Given this list of marker genes Tek, Abcb1b, Prr5, Tamm41, Vta1, Cfap54, Brf2, Itgb4, Plscr2, Cbfa2t3, Dvl3, Phpt1, Gcat, Krt10, Gstm3, Arhgap32, Entrep3, Shfl, Epyc, Fnbp1l, Tgif1, Il12rb1, Nlrp4b, Tcea2, Osbpl3, Tsks, Chchd6, Zcchc3 (zinc finger, CCHC domain containing 3), Ush2a, Ppil4, Ncam2, Dusp7, Nkain1 (NCBI Gene Id 72746), Snord8 (small nucleolar RNA, C/D box 8), Csn1s2a, Parm1, Glycam1, Klf4, Ift22, Rrp1b, Cd93, B630019K06Rik, Dag1, Pcmtd1 (NCBI Gene Id 71455), Rhbdd2, Gimap5, Rab37, Acad9, Nt5c3b, Trp53rkb, Fnbp4, Abcf2, Lgi4, Rmnd1, Pik3ip1, Kifbp, Mylk, Smad9, Pskh1, Gm7967, Irak1, Prkch, Armc10, Crem, Tmtc2, Dip2c, Rnf138, Arhgef2, Mgat3, Gata2, Plekhf1, Igf2bp1, Mtf2, Ptprcap, Garin5a, Ergic1, Zbtb38, Gm8883, Ptpdc1, Fhl4, Ppic, Ptgds, Afap1l1, C4b, Ptov1, Abi2, Acad8, Fbxw24, Wdr19, Bvht, Abcb11, Lgals3bp, 2410018L13Rik (RIKEN cDNA 2410018L13 gene), Capsl, Casp8, Kank2, Gadd45b (growth arrest and DNA-damage-inducible 45 beta), Nrgn, Clasrp, Pou2f2, Abl1, Rhobtb3, Rapgef5, Slc39a6, Trim32, D630045J12Rik, Mef2c, Gm11844, Pafah2, Hspa1l, Acot2, Cdk9, Ccdc90b, Slc12a7, Vwa8, Ino80e, Zfp326, Lhpp, Ifi203, Ascl1, Arhgef17, Tmem135, Slc1a1, Nell1, Tmsb10, Endou, Il11ra1, Tnik, Ushbp1, 1700092E19Rik, Rlim, 2310002L09Rik, ENSMUSG00000137801, Hoxa6, Sox4, Taf4b, Thsd1, Snapc1, Slc4a1ap, Smyd5, Gm31597, Dnajb9, Ccar1, Hoxa9, Sh2b1, Repin1, Crtc1, Pdcd6ip, Ptx4, Fgf18, Cwf19l1, Mdga1, Saraf, Nrg4, Actr3b, Miga1, Gja1, Hes2, Spart, Cep170b, Ttc27, Zmym4, Tnfaip8l1, Phc1, Rpusd4, Sms (spermine synthase), Fzd8, Terf2, Hmox2 (NCBI Gene Id 15369), Lats2, Ago1, Smo, Lrrc1, Gm11772, Anxa10, Stox2, Ccnd2, Efna1, Spred1, Pemt, Hoxa4, Alkbh6, Ctla2b, Per2, Dnajc1, Tymp, Avpi1 (NCBI Gene Id 69534), Hs1bp3, Clca2, Eva1b, Usp2, Hephl1, Epb41l4b, Rbakdn, Plxdc2, Rnf217, Gm27343, Rassf2, Ecpas, Ltbr, Sytl4, Hmga2, Mmp23, Egln3, Fchsd2, Plppr2, Asrgl1, Lix1l, Plppr3, Spmip6, Art1, Mn1 (NCBI Gene Id 634779), Elovl6, Serpinf1, Gemin5, Septin1, Acnat2 (acyl-coenzyme A amino acid N-acyltransferase 2), Tfpi, Naa25, Nwd2, Adgrl4, Norad, Gbp3, Mlxipl, Fbln2, Ttc21b (NCBI Gene Id 73668), Klhl3, Slc4a8, Zpbp, Arhgef5, Deptor, Prdm5, Dhtkd1, Islr2, Syde1 (synapse defective 1, Rho GTPase, homolog 1 (C. elegans)), E130311K13Rik, Slc25a36, Snx30, Dnmt3b, Kdelr1, Cand2, Usp30, AU020206, Pkp4, Msi2, Usp28 (NCBI Gene Id 235323), Cpeb1, Kcnc1, Mlec, Hic1, Scn8a, Fgf10, Foxb1, Aldh5a1, 9030619P08Rik, Nop14, Ptprm, Ipo4, Gulp1, Nalf1, Hmgn5, Tctn1, 4933406I18Rik, Cyp4v3, Ift46, Acsm1, Tnfsf10, Ntrk3, Pgpep1 (pyroglutamyl-peptidase I), Dagla, Tamalin, Csrnp1, Cend1, Tpk1, Tes, Paip2b, Ttc22, Mtor, G730003C15Rik, Cnrip1, Grp, Mprip, Ints12, Enah, Ralgapb (Ral GTPase activating protein, beta subunit (non-catalytic)), Ceacam12, Pnpla6, Nav1, Zfp704, Taok3, Gpr15lg, Uqcc1, Gimap6, Akap6, Kifap3, Lingo3, Rwdd3, Ildr2, Cd27 (CD27 antigen), Rps25, Obp2a, 4930444F02Rik, Armcx2, Etv6, Slc35f2, Nek6, Esam, Prss8, Fkbp3, Gstm1, Sestd1, Fabp9, Amer1, Bnip5, Stxbp1, Zfp787, Kcnmb1, Phf3, Prkce, Spock2, Stambp, Dicer1 (dicer 1, ribonuclease type III), Atf6b, Pogk, Klf12, Uba52, Dusp12, Hdhd5 (NCBI Gene Id 94046), Syt11, 1700025G04Rik, Kat2a, Pdrg1, Zfp629, Pgm1, Ube2e2, Cnot1, Bod1, Taf1d, Glis2, Mccc1, Apoa5, Zfp945, Mfng, Fads2, Firre, Dapk1, Kcnj14, Tmem176b, Zfp12, Mtmr10, Gmppb, Smad1, Ddx11, Fzd6, Sod2, Exoc3l2, Gm5602, 2810403D21Rik, Fbxo21, H2-Q10, Ift56, Carmil2, Cibar1, Zfp827 (zinc finger protein 827), Meis1, Hint2, Gprasp2, Hp1bp3, Itpr1, ENSMUSG00000143154, Gpn1, Rs1, Cbfa2t2, Eprs1, Flt3, Fbxw11, Fkbp1a, Zfp422, Flnb, Wnt6, Clip4, L3hypdh, Fasn, Cysltr1, Htr2a, Mus81, Dennd2d, Trp53i11, Tacr2, Hnrnpu, Gimap9, Pitpnm2, Kctd1, Ears2, Spmip10, Galnt11, Pgrmc1, Arl3, Tcerg1l, Midn, Rcn2, Prl2a1, Meaf6, Nkapd1, Gopc, Pced1a, Zxdb, Mpped2, Gm30431, Dhdh, Hspa4, 2900026A02Rik, Slc17a5, Itgb8, Slc5a6, Rhobtb1, Sfr1, Npl, Fam43a, Dlg3, Gtf3c6, Kremen1, Prss12, Rbmy, Tbc1d16, Insr, Ankrd37, Nipsnap1, Clec14a, Akr1b7, Lrrc58, Adgrg1, Ivns1abp, Limd2, Ada, Mxd4, Kazn, Syngr1 (NCBI Gene Id 98000), Krt18, Kit, Ttpa, Btc, Mapk6, Disp1, Arpp19, Fbxl19, Mrpl19, Hic2, Bfar, Ctbp2, Rnf152, Adrb3, Gm36208, Zbtb10, Plekha3, Ccdc85b, Mical2, Trbv1, Ret, Huwe1, Ptpn20, Cisd3, Smad5, Map1s, Tmem106c, Mier2, Fgd5, Reg2, Zfp260, Nsg1, Sh3pxd2b, Arl5b, Gm49760, Arxes2, Ap5z1, Rab26, Sufu, Zmiz1, Guca1b, Coro2a, Mbtd1, Gabpa, Runx2, D16Ertd472e, Muc1, Irf2bpl, Bphl, Fstl5, Tmem201, Slc7a6, Lratd2, Bcl2, Ocrl, Plekha5, Camk2a, Poc5, Sigirr, Sema5b (NCBI Gene Id 20357), Smim11, Zfp503, Qser1, Gzmd, Acsf3, Yju2, F2rl3, Car13 (NCBI Gene Id 71934), Gm42067, Bcl2l14, Wdr72, Spink10, Qsox1, Nop58, Acadl, Rab38, Tle6, Khdrbs3, Tle4, En2, Mamdc2, Edil3, Zfp521, Plac9 (NCBI Gene Id 353370), Syde2, Gnasas1, Cldn8, Ylpm1, Amigo2, Usp40, Noxo1, Ldhd, Pex1, Hsd3b7, Smarcc1, Bsn, Med11, Mycn, Asah2, Siae, Faap20, Ly6g2 (NCBI Gene Id 223631), Ccdc93, Gnaz, Tgtp1, Eid2, Dll1, Gm4631, A930041C12Rik, Nap1l3, Bend4, Pcp4l1, Baz1b, C2cd2, Cebpz, Prrc2c, 9930012K11Rik, Prtg, Rbpms, Pomgnt2, Peak1, Ndn, Mpl, Sh2b3, Nufip1, Magi2, Abcc1, Zfp157, Arhgap35, Bysl, Ncs1, Pdcd4, Ttc9, Mipol1, Calr, Armh3, Atxn3, Itga6, Cracd, Nppc, Gpx5, Dnajc2, Rbbp9, Krtap31-1, Tnni1, Slc50a1, Aven, 4833445I07Rik, Coa7, Xxylt1, Gpr62, Dcbld1, Gm11400, Man2a2, Ubash3b, Spaca9, Vegfb, Naxe, Slc43a2, Krba1, Fut8, Kcnd3, Sla2, Wnt11, Gstk1, Pcdh7 (NCBI Gene Id 54216), here is a description of the gene set: Genes in the expression cluster 'HSC and Progenitors Shared': up-regulated in hematopoietic stem cells (HSC) and progenitors from adult bone marrow and fetal liver. from publication Ivanova NB, Dimos JT, Schaniel C, Hackney JA, Moore KA, Lemischka IR (PMID 12228721) Mouse Gene Set: IVANOVA_HEMATOPOIESIS_STEM_CELL_AND_PROGENITOR species: Mus musculus Mechanisms regulating self-renewal and cell fate decisions in mammalian stem cells are poorly understood. We determined global gene expression profiles for mouse and human hematopoietic stem cells and other stages of the hematopoietic hierarchy. Murine and human hematopoietic stem cells share a number of expressed gene products, which define key conserved regulatory pathways in this developmental system. Moreover, in the mouse, a portion of the genetic program of hematopoietic stem cells is shared with embryonic and neural stem cells. This overlapping set of gene products represents a molecular signature of stem cells.